The following is a description of a gene set: Human Gene Set: PPARA_01 studied in species Homo sapiens Genes having at least one occurrence of the motif CARAACTAGGNCAAAGGTCA in the regions spanning 4 kb centered on their transcription starting sites. This matches the PPARA transcription factor binding site V$PPARA_01 (v7.4 TRANSFAC)., and this is the list of marker genes: TOMM70, NR2F6, MARCHF10, PGF, SAMD14 (NCBI Gene Id 201191), ZNF547, GPR52, PTPRG, ETFB, DNAJA2, PEX16, CACNB1, KLF5, PDZK1, PPARGC1A, ATN1, TNS1, BICC1, ESRRA, SRC, HNRNPH3, PRDM16, MASP2, HOXD3, CALCOCO1, CD36, HMGCS2 (3-hydroxy-3-methylglutaryl-CoA synthase 2), CDIN1, CDK16, PAPLN, MYH10, RPL19, RTN4, SLC23A3, SS18, FBP2, MLLT6